The following is a description of a gene set: studied in species Homo sapiens Pathway Definition from KEGG: CX3CL1 -> CX3CR1 -> GNAI -| ADCY -> cAMP -> PKA Human Gene Set: KEGG_MEDICUS_REFERENCE_CX3CR1_GNAI_AC_PKA_SIGNALING_PATHWAY CX3CR1-GNAI-AC-PKA signaling pathway. Pathway ID: N00403. Pathway type: Reference. Pathway class: nt06167 Human cytomegalovirus (HCMV)., and this is the list of marker genes: ADCY8, ADCY7, CX3CR1, ADCY2, GNAI3, ADCY4, PRKACA, GNAI2, PRKACB, ADCY1, GNAI1, CX3CL1, ADCY3, ADCY6, ADCY5, PRKACG, ADCY9